Given this list of marker genes Catsper4, Hvcn1, Catsperd, Catsperb, Catsperg1, Catsper1, Catsper3, Kcnu1, Catsper2, here is a description of the gene set: studied in species Mus musculus Sperm Motility And Taxes Mouse Gene Set: REACTOME_SPERM_MOTILITY_AND_TAXES